Given this list of marker genes Slc25a42 (solute carrier family 25, member 42), Adcy10 (adenylate cyclase 10), Slc25a25, Abcc6, Panx1, Calhm4, Slc25a54 (NCBI Gene Id 74686), Cd47, Ank, Slc17a9, Slc35b1, P2rx7, Calhm2, Slc25a31, Slc25a23 (solute carrier family 25 (mitochondrial carrier; phosphate carrier), member 23), Slc25a24, Calhm5, Slc25a17 (NCBI Gene Id 58177), Gja1, Calhm6, Calhm3, Slc25a41 (NCBI Gene Id 103775), Slc25a4, Calhm1, Slc25a5, here is a description of the gene set: studied in species Mus musculus The directed movement of ATP, adenosine triphosphate, into, out of or within a cell, or between cells, by means of some agent such as a transporter or pore. Mouse Gene Set: GOBP_ATP_TRANSPORT